The following is a description of a gene set: Human Gene Set: MCCLUNG_COCAIN_REWARD_4WK Genes up-regulated in the nucleus accumbens (a major reward center in the brain) after 4 weeks of cocaine treatment. from publication McClung CA, Nestler EJ (PMID 14566342) DeltaFosB (a truncated form of FosB) and CREB (cAMP response element binding protein) are transcription factors induced in the brain's reward pathways after chronic exposure to drugs of abuse. However, their mechanisms of action and the genes they regulate remain unclear. Using microarray analysis in the nucleus accumbens of inducible transgenic mice, we found that CREB and a dominant-negative CREB have opposite effects on gene expression, as do prolonged expression of DeltaFosB and the activator protein-1 (AP-1) antagonist DeltacJun. However, unlike CREB, short-term and prolonged DeltaFosB induction had opposing effects on gene expression. Gene expression induced by short-term DeltaFosB and by CREB was strikingly similar, and both reduced the rewarding effects of cocaine, whereas prolonged DeltaFosB expression increased drug reward. Gene expression after a short cocaine treatment was more dependent on CREB, whereas gene expression after a longer cocaine treatment became increasingly DeltaFosB dependent. These findings help define the molecular functions of CREB and DeltaFosB and identify clusters of genes that contribute to cocaine addiction. studied in species Mus musculus, and this is the list of marker genes: TUG1, CORO2B, SOX11, SHE, IL1R2, FOS, ZNFX1, SERPINB2, DCLRE1A, DNAJC5, ZDHHC6, KIN, UGDH, ADA, IL3, TRAF6, INHBC, CAPN6, CBLIF, ACTR1A, PBX1, SERPINA1, DUSP1 (NCBI Gene Id 1843), TCF3, CORIN, COL10A1, ITPR2, SIRT1, UNC119B, P4HA1, FNDC1, NCS1, PDXK, SLC22A5, KLF4, KIF1B, NFATC2, GPAA1, SMARCA4, COL8A1, SMR3B, NR4A1, KLF5, DUSP6, GUCA2A, CCDC6, AASS, NUSAP1, SLC35D1, RANGAP1, CYBC1, SERPINB3, CAMK2A, TECTB, ZAP70, EPB41, KLF10, CLK1, APOH (NCBI Gene Id 350), SWAP70, FMR1NB, CIAO2B, DNAJB1, PDPK1, CRYGD, IL17A, CAMLG, PAPOLA, ANKHD1, NELL2, PER1, PISD, BLK, WNK1 (WNK lysine deficient protein kinase 1)